Given this list of marker genes SLC25A38, RCN2, RBM47, ITPR1, TAF6L, PDLIM7 (PDZ and LIM domain 7), TRIT1, CD80, VPS9D1, FOXRED2, FAM219A, H2AZ1 (NCBI Gene Id 3015), LEPROT, LPIN2, SERINC3, SERF2, KIF5A, METRNL, HIPK2, SFMBT1, ORAI3, DYNLT1, AARS1, HACD2 (3-hydroxyacyl-CoA dehydratase 2), CD38, VEGFB, LARS1, JDP2, STOM (stomatin), TBXAS1, CYSLTR1, SH3BP5L, KIF20B, MAP2K6 (mitogen-activated protein kinase kinase 6), TTK, DNMT1, TMPO, PDIA3, VAMP3, CENPI, LAPTM4B (NCBI Gene Id 55353), ABRAXAS2, SYNRG, PTPA, PDIA6, FANCL, AKT1, DHX32, CCDC34, PPP1R11 (protein phosphatase 1 regulatory inhibitor subunit 11), ZCCHC3, ABL1, CCDC88A (NCBI Gene Id 731560), TSPAN31, LAMTOR1, INCENP, PLEKHO2, SLC22A5, CFAP410 (NCBI Gene Id 755), ATAD2, ZDHHC23, IQGAP3, CASP7, KCTD14 (NCBI Gene Id 65987), CDC14A, ADCY4, ARHGAP18, IGSF6, QSER1, CRIP1, ATXN1L, AURKA, SYPL1, C2CD2L, MIR22HG, TMBIM1, BCL2L14, COPG2, VKORC1L1, COQ2, TOR3A, CHST11, SPINT1, E2F3, UGGT1, NDRG1, EFCAB14, MAPKAPK2, LSR, CENPF, YIF1B, MTMR14, CTC1, CORO1B, IL3RA, MCUB, NDST2, PRR5, SPAG9, GCA, SKA2, MAGT1, TSPAN2, PMF1, DOCK5, GNAQ, PRRG2, CD99L2, DYNLT2B, PALB2, CYB561A3, FUCA2, BST1, ABHD12, CLVS2, UBTD2, ENPP5, SERPINB9, IMPA2, HPS3, DCLRE1A, ERCC6L, DHRS13 (dehydrogenase/reductase 13), TEP1, MTCH1, DPY19L1, SOX12, EXTL3, RAB14, WBP1, MIS18BP1, INPPL1, PLPP5, OAT, GNG12, GAMT, SLC33A1, ARL5A, NUCB2, GALC, APIP, ACER3, ASAP2, KIF22, SOCS5, PTPRJ, LPCAT1, NDC1, ARL6, PYGO2, PARVG, LONRF1, NEDD4, TRAPPC9, LUZP1, TUSC1, RTL5, GKAP1, ALMS1, RPS6KA5, DPAGT1, ARHGEF6, SLC35A3, SIPA1L3, FARP2, SPAG5, BUB1B, LTBR, RAD51D, ALDH16A1, NADK, PRRC1, AHR, CTNNBIP1, SLC9A9, CENPP, PTMS, PRDX4, DAGLB, SEPTIN10, RCAN1, NLRP3, UBE2G2, EVI2B, RAB11FIP5, UBA6, ACOX3, TTC7A (tetratricopeptide repeat domain 7A), C4orf19, STARD8, HLCS, ZC3H12C, TRAM2, PLSCR1, GCNT1 (glucosaminyl (N-acetyl) transferase 1), GMNN, YWHAG, CAPZB, PKIG, CACNA1S, here is a description of the gene set: Goals/objectives: to identify various gene expression in B cell subsets derived from human PBMC and cord blood Human Gene Set: GSE17186_NAIVE_VS_CD21HIGH_TRANSITIONAL_BCELL_DN studied in species Homo sapiens from publication Suryani S, Fulcher DA, Santner-Nanan B, Nanan R, Wong M, Shaw PJ, Gibson J, Williams A, Tangye SG (PMID 19965666) Genes down-regulated in B lymphocytes: naïve versus transitional CR2 high.